The following is a description of a gene set: Human Gene Set: GOMF_PHOSPHATIDYLINOSITOL_4_5_BISPHOSPHATE_PHOSPHATASE_ACTIVITY Catalysis of the reaction: 1-phosphatidyl-1D-myo-inositol 4,5-bisphosphate + H2O = 1-phosphatidyl-1D-myo-inositol phosphate + phosphate. species: Homo sapiens, and this is the list of marker genes: INPP5K, INPP5E, OCRL, INPP5D, SYNJ2, SYNJ1, INPP5B, INPP5J, FIG4, PTPMT1, PIP4P2, PIP4P1